Given this list of marker genes SFTPB, here is a description of the gene set: studied in species Homo sapiens part of: Diseases associated with surfactant metabolism Reactome Pathway: Defective pro-SFTPB causes SMDP1 and RDS Pulmonary surfactant-associated protein B (SFTPB), amongst other roles, is a component of surfactant, a surface-active film that helps reduce surface tension in alveoli. Defects in the SFTPB gene result in loss-of-function SFTPB proteins and accumulation of partially-processed, inactive pro-SFTPC in alveoli. Defects in SFTPB can cause pulmonary surfactant metabolism dysfunction 1 (SMDP1; MIM:265120), a rare lung disorder due to impaired surfactant homeostasis characterised by alveoli filling with floccular material. Excessive lipoprotein accumulation in the alveoli results in a form of respiratory distress syndrome in premature infants (RDS; MIM:267450).